The following is a description of a gene set: An adenylate cyclase-inhibiting G protein-coupled receptor signaling pathway initiated by dopamine binding to its receptor, and ending with the regulation of a downstream cellular process. species: Homo sapiens Human Gene Set: GOBP_ADENYLATE_CYCLASE_INHIBITING_DOPAMINE_RECEPTOR_SIGNALING_PATHWAY, and this is the list of marker genes: ADCY5, DRD4, DRD2, PRMT5, DRD3, FLNA